The following is a description of a gene set: studied in species Homo sapiens Human Gene Set: HP_ABNORMAL_NASAL_MUCOSA_MORPHOLOGY Abnormal nasal mucosa morphology, and this is the list of marker genes: DNAAF4, UNC119, CFAP298, DNAI2 (dynein axonemal intermediate chain 2), CEACAM6, SMAD4, HMOX1, AIRE, PTGER2, DNAH9, RSPH4A, SLC9A3, TBX21, DNAL1, TAP2, EDNRA, FCGR2A, HFE, SERPINA1, SPAG1, CFTR, DNAH1, ODAD4, ACVRL1, GAS2L2, DNAAF6, MIF, DCTN4, BTNL2, CFAP74, STX1A, STK11, HYDIN, RSPH9, HLA-DRB1, CFAP300 (NCBI Gene Id 85016), ZMYND10, DNAAF3, GDF2, RPGR, ODAD1, DNAAF1, DNAH5, GSTM3, ODAD3, CLCA4, GCLC, DRC1, RSPH1, ECM1, NME5, TTC12, DNAAF11, TAP1, DNAH11, ENG, OFD1, NME8, ODAD2, CCDC39, STK36, FOXJ1, CFAP221, SLC11A1, LRRC56, NEK10, SLC26A9, DNAAF5, MCIDAS, SLC6A14, DNAAF2, TGFB1, KCNN4, CEACAM3, DNAJB13, CCDC40, CCNO, RSPH3, SPEF2, DNAI1